Given this list of marker genes LRRN4CL, METTL4, EFEMP1, CCR1, YPEL4, PLPP3, NDP, TIMM23B, MLLT10, TTC29, LAMA3, TMF1, NOMO2, CRACDL, CCDC68, NOMO3, SHISA7, NEMP2, ACVR1C, CSDE1, NKD1, FMO5, ECT2, CDH6, AXIN2, TMPRSS11D, NOMO1, KDM5A, CDH12, HPSE, KCNJ13, ZNF124, CTXN2, here is a description of the gene set: Genes predicted to be targets of miRBase v22 microRNA hsa-miR-6849-5p in miRDB v6.0 with MirTarget v4 prediction scores > 80 (high confidence targets). studied in species Homo sapiens Human Gene Set: MIR6849_5P from publication Chen Y, Wang X (PMID 31504780)